Given this list of marker genes Gabarapl1 (NCBI Gene Id 93738), Rbx1, Sdk1, Csmd3, Coq4, Ube2w, Pja1, Adm, Tat, Usp9x, Mob1a, Fmnl2, Nedd4l, Prph2, Afap1l1, Kpna3, Pde1c, Zscan20, Elovl6, Myh9, 4930544G11Rik, Rab21, Hacd3, Arhgap44, Cacnb4, Rab2b, Arid1b, Atad2, Zfp148, Zwint, P2ry10b, Mlxip, Lpp (LIM domain containing preferred translocation partner in lipoma), Tspan5, Adamts15, Dcaf10, Rimoc1, Ptprt, Smim13, Agfg1, Epha7, Lrp12, Myo10, Nlgn1, Ppip5k2, Hspd1, Abi2, Slc25a18, Snx19, Traf3, Gfpt1, Tnfaip8, Abhd14b, Hvcn1, Bmpr1a, Edf1, Zfp952, Cyb561d2, Sprr2h, Mindy2, Srsf3, Kcnn3, Apc, Cables1, Trip12 (thyroid hormone receptor interactor 12, NCBI Gene Id 73751), Ensa, Mtmr12, Rnf166, Bnip2, Kcnb1, Il1a (NCBI Gene Id 16175), Usp13, Cul3, Iqcj, Col14a1, Hbegf (NCBI Gene Id 225370), Lca5, Fkbp1b, Tbc1d2b, Vegfd, Slc35a1, Jchain, Ugp2, Ccdc15, Crip2, Rab8a, Susd5, Ubr5, Stx12, Cldn34b1 (claudin 34B1), U2surp, Upf3b, Pcdh19, Mprip, Sv2b, Luc7l3 (NCBI Gene Id 67684), Nufip1, Mpv17, Zbtb24, Ankmy2, Rasgrf2, Lpxn, Elovl5, Sppl3, Hhipl2 (hedgehog interacting protein-like 2), Ncor2, H6pd, Slc39a10, Camsap2, Asb1, Caskin1, Ntng1, Mllt3, Prrc2b, Atp5f1c, Zfp606, Slc4a11, Slc7a15, Ppargc1b, Ephb4, Cpsf2, Adck1, Upk1b, Naa60, Slc24a2, Fras1, Drg1, Arf3 (ADP-ribosylation factor 3), Art4, Tm6sf1, Ino80c (INO80 complex subunit C), Csnk1g3, Taok2, Snrnp35, Trub2, Zbtb43, Dcaf1, Tbcd, here is a description of the gene set: from publication Chen Y, Wang X (PMID 31504780) species: Mus musculus Mouse Gene Set: MIR_7649_5P Genes predicted to be targets of miRBase v22 microRNA mmu_miR_7649_5p in miRDB v6.0 with MirTarget v4 prediction scores > 80 (high confidence targets).